The following is a description of a gene set: studied in species Mus musculus Mouse Gene Set: GOBP_GENERATION_OF_PRECURSOR_METABOLITES_AND_ENERGY The chemical reactions and pathways resulting in the formation of precursor metabolites, substances from which energy is derived, and any process involved in the liberation of energy from these substances., and this is the list of marker genes: Nfatc3, Slc4a1, Sdhc, Idh1, Park7 (NCBI Gene Id 57320), Ppp1r1a, Myc, Cox7a1, Cox6a2, Hkdc1, Psen1, Ndufa2, Oas1f, Cox8b, Cox7c, Ndufb7, Pfkfb1 (6-phosphofructo-2-kinase/fructose-2,6-biphosphatase 1), Myog, Per2, Plec, Enpp1, Ndufb5, Abcd1, Pank2, Cox6b2, Gaa, Cox7a2l, Galt, Pklr, Etfdh, Gnmt, Ndufa6, Ndufa10, Pink1, Cavin3, Rpia (ribose 5-phosphate isomerase A), Ndufs3, Bpgm, Norad, Acat1, Ndufa1, Mcu, Dhrs2, Ndufb9, Prkaa1, Pdha1, Ifnlr1, Cox6a1, Suclg2 (succinate-Coenzyme A ligase, GDP-forming, beta subunit), Uqcrc1, Tafazzin, Ppp1r2, Gbe1, Uqcr11, Zbtb20, Chchd2-ps, Gyg1, Dyrk2, Hoxb3os, Tefm, Etfa, Adpgk (ADP-dependent glucokinase), mt-Nd3, Cox8c, Lep, Ins1, Pfkfb2, Il6st, Cyp1a2, Pgls, Mfn2, Gcgr, Igf2, Ucp2, Pgam1, Oas1h, Oas1b, S100b, Pygl, Atp5f1a, a, Ndufaf1, Prkag2, Il4 (interleukin 4), Chchd2, Mt3, Fkrp, Pfkm, Aldh1l1, Flcn (NCBI Gene Id 216805), Shpk, Ier3, Ppargc1a, Sdhaf4, Sdhaf2 (succinate dehydrogenase complex assembly factor 2), Epm2a, Pgk1, Slc27a5, Ugp2, Ndufb3, Mup4, Cs, Mup3, Apoc3, Idh3b, Akt1, Aldoa, Ndufv1, Ppp1r3b, Rpe (ribulose-5-phosphate-3-epimerase), Fdx2, Enox2, Bdnf, Trex1 (three prime repair exonuclease 1), Sucla2, Atp7a, Phkg1, Tyrp1, Nipsnap2, Coq10b (coenzyme Q10B), mt-Nd4l, Rubcnl, Hdac4, Uqcrh, Rptor, Kat2b, Aco1, Pgd, Blvra, Prps2 (phosphoribosyl pyrophosphate synthetase 2), Ep300, Cox8a, Ndufa7, Rbks, Cox10, Aco2, Aldoc, Fbp1, Pygb, Dlat, Sod2 (NCBI Gene Id 20656), Selenon, Acacb, Thap11, 4933405O20Rik, Pfkl, Ncor1, Eno3, Ndufab1, Ide, mt-Nd5, Ogdhl, Ppp1r3g, Gsk3a, Ccnb1-ps, Hk3 (NCBI Gene Id 212032), Gck, Pm20d1, Pnpt1, Gsk3b, Trpv4, Aldob, Ndufb6, Nr1d1, Trp53 (transformation related protein 53), Mtln, Mlst8, Atg2a, Ppp1cc, Pfkp, Phkg2, Trim63, Ppp1r3e, Ins2, Ndufv3, Snca, Atpsckmt, Hk2, Bid, Agl, Macroh2a1, 1700066M21Rik, Atp5if1, Mdh1b, Cdk1, Akt2, Ptges3, Mtfr2, Cox6b1, Pygm, Cox4i2, Dguok, Tkfc, Lipa, Tmem135, Oas1c, Eif6, Ppp1r3f, Nfatc4, Coa6, Slc2a6, Atp5mf, Stoml2, Crot, Hmgb1, Cox7a2, Cox5a, Atp5po, Idh3a, Opn3, Khk, Ogt, Bax, Slc25a13, Wdr45b, Grb10, Prkaa2, Pgf, Uqcrc2, Oas1e, Msh2, Pik3ca, Ndufb10, Ndufa11, Galk1, Prkaca, Ccnb1, Comt, Dnajc30, Mtfr1, Oas1d, Aldh1l2, Src, Adhfe1, Gys2, Eno1b, Pum2, Nr4a3, H6pd, Hmgcll1, Ndufs4, Ndufs6, mt-Co2, mt-Nd4, Pgk2, mt-Nd6, Ndufs2, Phka2, Gapdhrt2, Arl2, Mup1, Lepr, Tnf, Ppara, Hk1, Rb1cc1, Atg3 (autophagy related 3), P2rx7, Ldha, Ndufb8, Uqcrfs1, Mcur1, Ndufc2, Phkb, Wdr93, Pcdh12, mt-Co3, Sdhb, Uqcr10, Slc25a23, Sirt6, Pgam2, Eno4, Ucn, Mlx, Cox7b2, Sorbs1, Afg1l, Ndufv2, Cxxc5, Aifm2, Coq9, Oas1g, Gale, Cisd1, Ndufs8, Mrap2, Aifm1, Ndufs7, Antkmt, Il10rb, Sdhd, Abcc9, Vcp, Etfrf1, Hif1a, Pth, Dgat1, Tigar, Gapdh, Prdm16, Cycs, Iscu, Oxct1, Ndor1, Gpi1, Bloc1s1, mt-Nd2, Cyct, Jmjd8, Phlda2, Ndufb4 (NADH:ubiquinone oxidoreductase subunit B4), Csl, Wipi2, Dnajc15, App, Prkag3, Ppp1cb, Mir451b, Acox1, G6pd2, Pdhb, Ndufa8, Pde2a, Stat3, mt-Nd1, Nupr1, Mup11, Ak4, G6pc1, Gapdhs, Cat, Ndufb1, Chchd4, Esrrb, Rhoa, Idh2, Mfsd8, Mrps36, Wipi1, Gys1, Cox5b, Stbd1, Foxk2, Cbfa2t3, Uqcrq, Acadm, Adgrf1, Adrb1, Cox4i1, Ndufa13, Ppif, Actn3, Eno2, Wdr45, Slc25a25, Fxn, mt-Co1, Sco2, Uqcrb, Adra1b, Slc25a33, Prkag1, Igf1, Atp5f1c, Dlst, Adcy10, Aldoart1, Tkt, Gnas, Arnt, Mir451a, Ndufa9, Ndufb2, Ndufs1, 1810024B03Rik, Nkx1-1, Slc25a51, Rbpj, Gnpda1, Prlh, Mtch2, Ndufa5, Cyc1, Adgrf5, Stk40, Sdha, Zbtb7a, Ndufa3, Oxct2a, Adsl (adenylosuccinate lyase), Slc37a4, Aass, Ddit4, mt-Cytb, Ppp2ca, Gabarapl1 (NCBI Gene Id 93738), Mc4r, Hmgcl, Nhlrc1 (NCBI Gene Id 105193), Atg12, Mdh2, Ifnar1, Atp5f1b, Dhtkd1, Vps54, Pgm1, Bcl2l13, Inpp5k, Chchd10, Atp5f1e, Ppp1ca, Uqcc2, Suclg1, Prelid1, Atp5pd, Nop53, Shmt2, Slc25a12, Gpr180, Ndp, Kl, Ppp1r3a, Hsd11b1, Slc4a4, Eno1, Taldo1, Gba1, Ndufa12, Por, Mtor, G6pdx (glucose-6-phosphate dehydrogenase X-linked), Pask, Aldoart2, Mtfr1l, Irs2, Eva1a, Mup2, Mdh1, Atp5f1d, Lyrm7, Coq7, Fh1, Mlxipl, Tcf7l2, Mybbp1a, Ogdh, Cox6c, Nnt, Dld, Oas1a, Cox7b, Hmgcs2, Vgf, Il3, Pomc, Atp5pf, Fdx1, Ppp1r3d, Prps1, Pgm2 (NCBI Gene Id 66681), Gapdhrt, Oxa1l, Ndufs5, Pdha2, Htr2a, Col6a1, Trap1, Atp5pb (ATP synthase peripheral stalk-membrane subunit b), Pkm, Uqcc3, Sirt3, Tpi1, Ndufc1, Uchl1, Phka1, Idh3g, Gpd1, Sik2, Foxk1, Atp6-ps, Insr, C1qtnf2, Mup5, Gfpt1, Ppp1r3c, Prxl2c, Ifng, mt-Atp6, mt-Atp8, Pfkfb3, Atp5me, Irs1, Mpi, Etfb, Oxct2b, Epm2aip1, Atg2b, Git1, Ndufb11, Immp2l, Chchd5